Given this list of marker genes Manbal, Septin6, Snap25, Cdh13, Zfp322a, Igbp1, Fam193a, Mapk1ip1l, Prss36, Gtf2a1, Chrna5 (NCBI Gene Id 11439), Fgf12, Phc1, Iglon5, Gstt1, Prokr2, Ppef1, Saa4, Sorbs2, Pappa, Cap1, Rbm27, Fadd, Galnt7, Ncoa7, Itsn1, Irx4, Xk, Rslcan18, Slfn14, Nfatc1, Nap1l1, Has2, Acvr1, Cux1, Gsk3a, Gabrb1, Acnat1, Abcc4, Exoc3, Ino80, Cops5, Fbxl7, Rif1, Cdkn2d, Aplf, Shprh, Kif16b, Pcf11, Sgcz, Spib, Timm8b, Sema6a, Usp9x, Khnyn, Hectd4, Gpr83, H3f3b, Agxt2, Lrrc71, Grap2, Stambp, here is a description of the gene set: from publication Chen Y, Wang X (PMID 31504780) Mouse Gene Set: MIR_1188_5P species: Mus musculus Genes predicted to be targets of miRBase v22 microRNA mmu_miR_1188_5p in miRDB v6.0 with MirTarget v4 prediction scores > 80 (high confidence targets).